Given this list of marker genes Shfl, Eif5a2, Smyd5, Srp9, Mettl18, Rack1, Eif4a3, Eif4a3l2, Eif4a3l1, Alkbh1, Eif5a, Cpeb3, Secisbp2, Cpeb2, Usp16, Aars1, here is a description of the gene set: studied in species Mus musculus Any process that modulates the frequency, rate, extent or accuracy of translational elongation. Mouse Gene Set: GOBP_REGULATION_OF_TRANSLATIONAL_ELONGATION